Given this list of marker genes BRINP3, CACYBP, PSMA1 (proteasome 20S subunit alpha 1), THEMIS, DTNA, SLF2, ATP2B2, COX8A, RFLNB, GOLGA8H, SPINDOC, GOLGA6L9, DICER1, GRP, ZNF516, TENT5A, RAB3C, NR2E3, AMELY, ZEB2, SGCB, MLXIP, GOLGA8R, LYRM4, SLC16A10, TRIM23, SYNGR3, CAT, CALHM5, RB1CC1, CCNT2, BCL10, ZNF75D, GADD45G, CCND2, TXN, ZNF568, C16orf82, MMAA, PGPEP1L, TEX9, SGMS1, PIGQ, GFPT2, ARHGAP20, SNRPF (NCBI Gene Id 6636), ATP1B1 (ATPase Na+/K+ transporting subunit beta 1), FGFR2, LRP2BP (LRP2 binding protein), SGCE, RNF7, CBFB, RAI2, GHRH, UBE2E3, NETO2, AMOT (NCBI Gene Id 23340), ZBTB44, SNAI2, ZPR1 (NCBI Gene Id 95155), TP53, SLC25A20, NIPBL, CST6, SH3BGRL2, NDRG2, NR1D2, TNFRSF9, ZNF385A, SEMA3D, NCMAP, GRB7, GOLGA6L4, SLC30A5, DOK5, GOLGA6L10, MRPL37, COPB1, PARP14, PLPP7, UHRF2, DCTN3, TXNDC5, GABRG2, OLFM1, GOLGA8Q, PDIA3, NECAB1, CKMT2, ARID2, CHAC2, GOLGA8M, ARNT2, RAP1GAP2, PPP1R9B, FAT1, UPP2, PSMD3, MYO10, TWF1, SLC25A53, SERPINB5 (NCBI Gene Id 5268), DPAGT1, ETV5, PHEX, ANKRD36B, DDX46, CLIP2, ETV3, PRDM8, ATP6V0D1, CSRP3, PPP1R3A, NUFIP2, DENND4A, PCLO (NCBI Gene Id 56630), RGPD1, GNRHR, GBP7, GALNT18, UBFD1, ZNF585A, KIAA1191, HERC3, INTS3, SLC22A23, GABARAPL2, TET2, MRPL35, RXYLT1, EIF3A, LAPTM4A (NCBI Gene Id 9741), KCTD4, MT3, GSPT1, STAB1, DDIT4L, KRT17, MT1E, PLRG1, MN1, BLTP3B, CCDC126, PACRG, MAJIN, ZEB1, PALM2AKAP2, ZXDB, NRP1, POFUT1, ATP1B4, ATP8B1, KPRP, DCUN1D5, ATXN1, CNTN4, REPS1, VCP, ELK3, GOLGA8J, ZNF714, ELAVL4, MRPS18B, PRKCSH, HSPB7, ABRAXAS2, NHLRC3, RGS18, VSNL1, PABPC5, STRN3, GOLGA8T, CFL1, MYH10, ABTB2, HRNR, RAB2A, NAT16, LURAP1L, UROD, TPGS2, GOLGA8N, AEBP2, NKPD1, ZNF644, MAP1A, ADIPOR2, RTP2, AMELX, SNRPB2, CAPN6, IWS1, STAU2, ZNF780A, IL22, SEC61A2, FBXL3, UBE2D3, QSER1, TSHZ1, COL26A1, CDKN1B, LLCFC1, PRSS36, MLIP, RALGAPA1, NIN, DOCK2, ZNF777, GLIPR2, here is a description of the gene set: species: Homo sapiens from publication Chen Y, Wang X (PMID 31504780) Genes predicted to be targets of miRBase v22 microRNA hsa-miR-5701 in miRDB v6.0 with MirTarget v4 prediction scores > 80 (high confidence targets). Human Gene Set: MIR5701